Given this list of marker genes GFPT1, ORAI1, STIM1 (NCBI Gene Id 6786), GMPPB, ALG14, CASQ1, DPAGT1, ALG2, here is a description of the gene set: Human Gene Set: HP_MUSCLE_FIBER_TUBULAR_INCLUSIONS studied in species Homo sapiens Unusual regions of densely packed membranous tubules known as tubular aggregates which present as membranous inclusions, derived from membranes of sarcoplasmic reticulum and mitochondria, containing miscellaneous proteins with a variety of enzymatic activities. Muscle fiber tubular inclusions